The following is a description of a gene set: Genes up-regulated in naïve B lymphocytes versus plasma cells. Human Gene Set: GSE4142_NAIVE_BCELL_VS_PLASMA_CELL_UP In order to better understand the factors that regulate B cell differentiation upon exposure to antigen, we compares global gene expression profiles from naive B cells with antigen-specific plasma, germinal center, and memory B cells after immunization with the T-dependent antigen, NP-CGG. The memory B cell-enriched transcripts were then compared with memory T cell-enriched and hematopoietic stem cell-enriched transcripts in order to generate a transcriptional profile of self-renewal within the hematopoietic system. species: Homo sapiens from publication Luckey CJ, Bhattacharya D, Goldrath AW, Weissman IL, Benoist C, Mathis D (PMID 16492737), and this is the list of marker genes: MNAT1, RIMOC1, ST7L, RBMS2, ACOX1, TSG101 (NCBI Gene Id 89764), USP9X, AFF3, KLHL24, COQ10A, TRABD, RCOR3, SCARB2, PRRC2B (NCBI Gene Id 84726), CTSE, USO1, PDE6D, ATP1A2, PPM1L, GPD1, RETREG1, TSC22D3, GDI1, MIEN1, IFNGR1, FBXL3, MAGI3, RNASET2, PI4K2A, AKTIP, ANKEF1, STX16, UGP2, GTF2IRD1 (GTF2I repeat domain containing 1), DBP, ARHGEF15, MAP4K5, FAM89B, ACAD10, SMUG1, IFT80, IL1RAPL1, MED10, BCL2L15, EDEM3, RELCH, MBIP (MAP3K12 binding inhibitory protein 1), PELI2, DAZAP2 (DAZ associated protein 2), LDLRAP1, PRKX, RFTN1, ELF2, RAPGEF2, PJA1, ZMYM2, STX1A, LGALS4, LPO, SEPTIN9, NIPAL3, NAV1, LGALS8, F2, PFN4, RNF130, MEF2A, HMGCL, SEMA6D (NCBI Gene Id 80031), GM2A, IKZF4, ARSK, PRG4, TUBB3, ANG, ARHGAP30, FBXO6, PITPNM1, SLC15A1 (solute carrier family 15 member 1), ABTB1, FRMPD3, GPC5, TRAK1 (trafficking kinesin protein 1), AHR, SPATA1, APP, PON3, PEX13, DNAJB5 (DnaJ heat shock protein family (Hsp40) member B5), EVC, SLC4A9, PIGV, FOXJ2, CTSW, RASAL3, NTAQ1, OSBPL3, TBC1D8B, ZDHHC17, NIN, CHST12, AP1S2, SDC3, RBM33, KIF3B, CCNI, CCDC28A, CAMK1D, STAC2, MATN1, PIP5KL1 (NCBI Gene Id 138429), YPEL2, OSTM1, ARHGAP8, PRR5L, CNDP1, ACOT13, PLD2, B3GNT8, ZFP90, MYOF (NCBI Gene Id 26509), SLC17A7, CREBRF, LRRC41, CACFD1, ZNF250, ATOSA, LGALS1 (galectin 1), IQGAP1, TMEM184B, CBFA2T2, GAB3, PHF20L1, HAGHL, DGKH, EPB41L2, HBP1, ZFAND6, ATP1B1, SS18, C17orf99 (chromosome 17 open reading frame 99), SETD7, VPS28, YPEL5, TAX1BP3, RBM11, CLDN7, DNAAF9, MROH1, AFAP1L1, PHKG2, METTL27, KCTD14, CFAP418, SERINC5, GPX8, FMNL3, SLC18B1, DNAJB14, MPZL1, PIP4P1, ULK2, MBD6, FAM78A, TBL1XR1 (TBL1X/Y related 1), RAB33B, TSPO, TDRD12, SESTD1, RALGAPB, CRYGS, USP22, EZH1, CGGBP1 (CGG triplet repeat binding protein 1), ITGB2, ZBTB24, COPS2, BMPR2, PPOX, GTPBP2, MNT, STON1, CAMK2G, MAP4K4, RBP1, FAM210B, ABI1, TAX1BP1, SNORD89, GOLGA2, UCKL1 (uridine-cytidine kinase 1 like 1), HOPX, ERC1, ABRAXAS2, SNX32, HMBOX1 (NCBI Gene Id 79618), CRTC3 (NCBI Gene Id 64784), CNIH1, SMAD7